The following is a description of a gene set: Neutrophil abscess formation is critical in innate immunity against many pathogens. Here, the mechanism of neutrophil abscess formation was investigated using a mouse model of Staphylococcus aureus cutaneous infection. Gene expression analysis of S. aureus-infected skin revealed that induction of neutrophil recruitment genes was largely dependent upon IL-1beta/IL-1R activation. Unexpectedly, using IL 1beta reporter mice, neutrophils were identified as the primary source of IL-1beta at the site of infection. Furthermore, IL-1beta-producing neutrophils were necessary and sufficient for abscess formation and bacterial clearance. S. aureus-induced IL 1beta production by neutrophils required TLR2, NOD2, FPRs and the ASC/NLRP3 inflammasome. Taken together, IL-1beta and neutrophil abscess formation during an infection are functionally, spatially and temporally linked as a consequence of direct IL-1beta production by neutrophils. Human Gene Set: GSE36826_WT_VS_IL1R_KO_SKIN_STAPH_AUREUS_INF_DN from publication Cho JS, Guo Y, Ramos RI, Hebroni F, Plaisier SB, Xuan C, Granick JL, Matsushima H, Takashima A, Iwakura Y, Cheung AL, Cheng G, Lee DJ, Simon SI, Miller LS (PMID 23209417) Genes down-regulated in lesional skin biopsies after S. aureus infection: wildtype versus IL1R1. species: Homo sapiens, and this is the list of marker genes: LXN, B3GNT2, CD47, SLC31A2, WARS1, FZD5, PML, CD59, ICOS, APOL1, BATF, CCSER2, LAP3, HEXA, CYRIA, PHACTR4, TNFAIP2, LAG3, CD80, MIA, DHX58, USP18, IGF2R, TAP1, KIAA0040, ATOX1, ETNK2, PDGFRA, LIMK2, GTPBP1, MAOA, RBMS2, MMP25, ICAM1, CNTNAP1, USP11, BMAL2 (basic helix-loop-helix ARNT like 2), PLTP, STAT5A, BNIP3, ZMYM6, TNFAIP3, SNX10, PLGRKT, LAMC1, OASL, ABI1, AKAP3, IL18BP, SERPINH1, MIA3, CLEC2D, MYH11, ELMO2, CNR1, STEAP3, JUN, FSCN1, ADAR, SIGLEC1, FOLR2, POMP, DRAM1, BSPRY (NCBI Gene Id 54836), KIFAP3, CKB, TSFM, ADRB2, MTERF1 (mitochondrial transcription termination factor 1), SP110, TUBB2A, KLF3, HLA-E, SRI, BASP1, RTP4, MYO10, KLHL36, RBM38, HSPA2, ATP13A2, IFITM2, AK4, AMDHD2 (NCBI Gene Id 51005), MACROH2A2, ECM1, BHLHE40, PPARA, SLC2A6, ACP2, OR7E36P, PTPN1, LBP, LRP10, SELENOW, IPO13, CASP6, PSME2, PVR, DSC2, CCL8, YJU2, FPGS, RSU1, SLC25A28, VPS9D1, CARM1, ISOC2, UGP2, XPNPEP1, RBMS1, UBB, ISG15, ADAM19, NECTIN2, PDCD1LG2, IGF2BP3, COA1, TDRD7, CLN5, PCNX1, ERLIN1, FSTL3, IFIH1, C1R, C1GALT1C1, CFLAR, VAC14, BLVRA, SOCS3, IFITM1, PLA1A, EPB41L2, RSAD2, TNF, MX2 (MX dynamin like GTPase 2), IGFBP7, HSPB1, TRADD, GADD45B, RELA, KDM4D, FSTL1, PEBP1, SLC1A2, RIPK2 (receptor interacting serine/threonine kinase 2), CFD, SEPTIN8, CDK4, STOML1, ENPP2, DOCK1, HESX1, SCO2, SECTM1, TMEM132A (transmembrane protein 132A), TGM2, DEPP1 (DEPP autophagy regulator 1), CDR2, NCDN, DTNB, RNF115, NINJ1, LHFPL6, LDHA, PLAAT4, GPD2, SYNPO, FCGR1BP, HERC6, GUCY1A1, NUP62, PAM, FCHSD2, P4HA2, CXCL10, PHF11, PLSCR1, SCN1B, SPATS2L, PIGB, CAMK1G, MCL1, TRIM21, CNTLN, RFTN1, PLD1, ABRAXAS2, APOL6, GPR137B, TNFAIP6, YBX3, ENSG00000291006, BATF3, MX1, ATP2B4, UNC13B, DYNLT1 (dynein light chain Tctex-type 1), PDE4B, ARID5A